Given this list of marker genes CFAP53, SPEF2, RIMBP3C, LZTFL1, LRGUK, IFT20, PPP1R42, IFT88, CFAP221, SNAPIN (SNAP associated protein), PACRG, MEIG1, STK33, IQCG, SPAG17, CCDC181, SPMIP6, CCDC42, CEP131, CCDC38, RAN, ODF1, RIMBP3B, RIMBP3, STRBP, here is a description of the gene set: Human Gene Set: GOCC_MANCHETTE studied in species Homo sapiens A tubular array of microtubules that extends from the perinuclear ring surrounding the spermatid nucleus to the flagellar axoneme. The manchette may also contain F-actin filaments.